Given this list of marker genes NOVA2, CASP1, TAT, TOM1, ITPR3, CHRNB1, PLA2G4A, ENTPD3, IFI35, PTPRE, CHD4, BRDT, ACAA2, FAM149A, RALGDS, TSHR, CD7, TNFRSF1B, NR3C1, IL1RL2, PIAS2, ELF4, PSEN1, F3, ALAS2, DHRS7, PHKG2, ABCC2, AQR, FOSL2, TTLL5, R3HDM1, MAN2B2, G6PC1, RBPJ, H2BC4, TSBP1, INSIG1, PDC, IGF1R, HSD3B1, SOX10, TNFRSF10B, TSPYL2, PCDHB11, NUP214, CCL3, BCLAF3, SPAG1, SAA1, HEXB, TMEM47, FAM131A, IL2RG, LPXN, NAPG, SIRPB1, ZNF205, GPS2, GSTO1, RPLP0, RFPL1S, DHRS3, ADAM18, PBX3 (NCBI Gene Id 5090), AP3S2, CEBPD, S100A11, YWHAE, BCAT2, RBP4, NDRG4, TAC1, NME6, CD5, PNP, GPX4, CLCA1, GRIK3, SMARCE1, BTF3P11, ART3, CD24, ARFIP2, COL10A1, BBS4, ELAVL4, RAP1GDS1, DNM2, TLR3, TMPRSS15 (NCBI Gene Id 5651), TUBA4A, RGS16, KDM7A, OTC, SLC22A2, GALNT3, PABPC4, SPATA31F2P, FCN3, HRC, RGL1, DENND5A (NCBI Gene Id 23258), GNAQ, HOXB2, GBX1, KBTBD11, WIF1, GPR68, CDK6, AKAP12, CD58, KIAA0513, NPAS3, GINS1, MARCKS, CXCL2, GABRA5, NDUFA7, CTH, H3C11, VAC14, MYC, SERPINB9, AKR7A3, PLAAT3, ABHD5, JRK, PI4KB, LEPR, ZNF202, EREG, PNLIPRP2, GRB7, GCHFR, S100A7, IGKV1D-13, LRRTM2, NET1, SS18, CCPG1, SIPA1L1, SLC25A24, IL2RB, CIB1, FXR1, SPATA2, REL, PON3, MINDY2, ACTC1, GDF11, KIF17, RPE65, SPICE1, PRKX, RPS12, KCTD12, TCF4, OLR1, GPC4, FLT1, UBE2B, HLA-DRB6, DDN, VCAN, SPTAN1, CEACAM6 (CEA cell adhesion molecule 6), SLA, PHTF1, PDIA6, ARAF, PPP4R1, MET, LAMA3 (NCBI Gene Id 3909), CFL1, CDV3, C4BPA, ZNF81, HFE, CUL2, CIITA, H2BC7, BMP3, CYP24A1, MYH9, RND3, SAFB2, GSN, COCH, CCL4, GYS2 (NCBI Gene Id 2998), SERPINC1, EPAS1, SSX1, FAM216A (NCBI Gene Id 29902), PLP2, CRTAM, ELK3, ENDOD1, here is a description of the gene set: Genes down-regulated in T reg: natural versus induced cells. from publication Haribhai D, Williams JB, Jia S, Nickerson D, Schmitt EG, Edwards B, Ziegelbauer J, Yassai M, Li SH, Relland LM, Wise PM, Chen A, Zheng YQ, Simpson PM, Gorski J, Salzman NH, Hessner MJ, Chatila TA, Williams CB (PMID 21723159) The relative contribution of induced and natural Foxp3+ regulatory T cells (iTreg and nTreg cells, respectively) to the maintenance of tolerance is unknown. We examined their respective roles by in vivo adoptive transfer immunotherapy of newborn Foxp3-deficient BALB/c mice. Survival, weight gain, tissue infiltration, T cell activation, and the concentration of proinflammatory cytokines were used as outcome measurements. Treatment with iTreg cells alone was not successful. While effective in preventing death, treatment with nTreg cells alone was associated with chronic inflammation and autoimmunity. Outcomes markedly improved when conventional T (Tconv) cells were transferred together with the nTreg cells, where 10% of the peripheral Treg cell pool was derived by in-situ conversion. This enhancement depended upon the capacity of Tconv cells to express Foxp3. The gene expression profile of in vivo derived iTreg cells was similar to the established nTreg cell genetic signature. These results identify iTreg cells as an essential regulatory subset that supplements tolerance maintained by nTreg cells. Human Gene Set: GSE19512_NAUTRAL_VS_INDUCED_TREG_DN species: Homo sapiens